Given this list of marker genes ICOSLG, TNFAIP2, NFKBIZ, SCHIP1, CXCL10, ADAMTS7, GBP2, SLC11A2, STX11, GBP6, SLC15A3, CXCL6, BIRC2, SH3PXD2B, SLC4A7, EGR1, OSMR (oncostatin M receptor), TJP2, CCL3 (C-C motif chemokine ligand 3), RFX5, REL, CD40, CXCL2, CASP4, LIF, EGR3, FAS, NEURL3, CCRL2, RSAD2, EREG, BTG1, NFKBIA, SELE, VCAM1, NFKBIE, RAB20, NFKB2, SOD2, PLK2, ICAM1, BIRC3, FOSL1, ZC3H12A, LRATD1 (NCBI Gene Id 654112), TNIP1, CCL7, GPR68, PRRX1 (paired related homeobox 1), SLCO4A1, TSLP, SERPINA3, PTPRE, MAFF, GADD45B, GSAP, NGFR, EXOC3L4, TNFAIP3, BMP2, EGFR, ZMYND15, TCIM, RND1, RIPK2, CXCL16, TLR2, ABCB1 (NCBI Gene Id 5243), CD44, CCL2, IER3, CSF1, CEMIP2, GCH1, EGR2, JDP2, here is a description of the gene set: from publication Seki E, De Minicis S, Osterreicher CH, Kluwe J, Osawa Y, Brenner DA, Schwabe RF (PMID 17952090) Hepatic injury is associated with a defective intestinal barrier and increased hepatic exposure to bacterial products. Here we report that the intestinal bacterial microflora and a functional Toll-like receptor 4 (TLR4), but not TLR2, are required for hepatic fibrogenesis. Using Tlr4-chimeric mice and in vivo lipopolysaccharide (LPS) challenge, we demonstrate that quiescent hepatic stellate cells (HSCs), the main precursors for myofibroblasts in the liver, are the predominant target through which TLR4 ligands promote fibrogenesis. In quiescent HSCs, TLR4 activation not only upregulates chemokine secretion and induces chemotaxis of Kupffer cells, but also downregulates the transforming growth factor (TGF)-beta pseudoreceptor Bambi to sensitize HSCs to TGF-beta-induced signals and allow for unrestricted activation by Kupffer cells. LPS-induced Bambi downregulation and sensitization to TGF-beta is mediated by a MyD88-NF-kappaB-dependent pathway. Accordingly, Myd88-deficient mice have decreased hepatic fibrosis. Thus, modulation of TGF-beta signaling by a TLR4-MyD88-NF-kappaB axis provides a novel link between proinflammatory and profibrogenic signals. studied in species Mus musculus Genes up-regulated in hepatic stellar cells after stimulation with bacterial lipopolysacharide (LPS). Human Gene Set: SEKI_INFLAMMATORY_RESPONSE_LPS_UP